The following is a description of a gene set: Human Gene Set: REACTOME_REGULATION_OF_ENDOGENOUS_RETROELEMENTS species: Homo sapiens Regulation of endogenous retroelements, and this is the list of marker genes: SMARCB1, H4C1, H4C5, ZNF418, ZNF519, MBD3 (methyl-CpG binding domain protein 3), H4C14, H2BC1, ZNF534, H3-3B, ZNF454, SMARCC2 (NCBI Gene Id 6601), UBE2I, ZNF816, ZNF778, MTA3, H3C11 (H3 clustered histone 11), SMARCC1, H2BC10, DPF1, EHMT1, ZNF680, H2BC12L, MTREX, H2BC11, ZNF33A, H2AB1, H2BC26, ZNF547, SUMO2, H2AC6, RBM7, DNMT3A, GATAD2B, DPF2, DNMT3L, SMARCD3, CHD3, H4C12, ZNF141, TASOR, ARID1A, SETDB1, ZNF136 (NCBI Gene Id 7695), H3C14, H3C7, ZNF264, MTA2, ACTB, H3C8, ZNF331, H2BC15, H2BC12, H4C8, H2BC7, H2AC18, ZCCHC8, ARID1B, H2AZ2, ZNF320, H4C13, HDAC1, H4C16, H2AX, TRIM28, H2BC6, RBBP4, ZNF317, H4C6, H3C4, H2BC13, H3C3, ZNF324, H2BC8, H4C9, ZNF382, BCL7B, H2BC3, ZNF30, ZNF354A, ZNF649, EHMT2, ZNF257, SMARCA2, SMARCD1, H2BC9 (H2B clustered histone 9), H2BC4, SMARCE1, MPHOSPH8, H2AC20, ZNF610, H3C12, ZNF425 (zinc finger protein 425), RBBP7, SS18, H2BC17, DPF3 (NCBI Gene Id 8110), HDAC2, H3C13, SS18L1, MORC2, H4C2, CHD4, GATAD2A, C19orf84, H4C3, CBX5, SMARCD2, H3-3A, BCL7C, H2BC14 (NCBI Gene Id 8342), H2AC7, PPHLN1, H2BC5, H3C6, ACTL6A, BCL7A, H4C4, H2AC19 (H2A clustered histone 19), H2AC14, ZNF669, ZNF28 (zinc finger protein 28), PIWIL4, ATF7IP, SMARCA4, H4C11, H3C15, ZNF224, H2BC21, ZNF765, H3C10, H2AC4, ZNF708, H2AC8, MTA1, H3C2, H3C1, H2AJ, ZNF93, SPOCD1, ZNF273, H4C15